Given this list of marker genes TBXAS1, PTGES2, PTGR2, PTGS1, AKR1C3, PTGDS (prostaglandin D2 synthase), PRXL2B, PTGIS, CYP8B1, CBR1, PTGES3, PTGES, HPGD, HPGDS, PTGS2 (prostaglandin-endoperoxide synthase 2), here is a description of the gene set: part of: Arachidonate metabolism Reactome Pathway: Synthesis of Prostaglandins (PG) and Thromboxanes (TX) The bioactive prostaglandin (PG) signalling molecules, including PGA2, PGE2, PGF2a, and PGI2 (prostacyclin) are synthesised from arachidonate and its products by various prostaglandin synthase type enzymes. Prostaglandin H2 (PGH2) is the starting point for the synthesis of Thromboxanes (TXs). PGs and TXs are collectively known as the prostanoids.<br>Two enzymes, PTGS1 and 2 (COX1 and 2) both catalyze the two-step conversion of arachidonate to PGH2. PTGS1 is constitutively expressed in many cell types while PTGS2 is induced in response to stress and mediates the syntheses of prostaglandins associated with pain, fever, and inflammation. Aspirin irreversibly inactivates both enzymes (though it acts more efficiently on PTGS1), explaining both its antiinflammatory effects and side effects like perturbed gastic acid secretion. Drugs like celecoxib, by specifically inhibiting PTGS2, have a strong anti-inflammatory effect with fewer side effects. These PTGS2-specific drugs, however, probably because of their effects on the balance of prostaglandin synthesis in platelets and endothelial cells, can also promote blood clot formation. studied in species Homo sapiens